The following is a description of a gene set: from publication Rhein P, Scheid S, Ratei R, Hagemeier C, Seeger K, Kirschner-Schwabe R, Moericke A, Schrappe M, Spang R, Ludwig WD, Karawajew L (PMID 17330098) species: Homo sapiens Genes down-regulated in ALL (acute lymphoblastic leukemia) blasts after 1 week of treatment with glucocorticoids. Human Gene Set: RHEIN_ALL_GLUCOCORTICOID_THERAPY_DN In childhood acute lymphoblastic leukemia (ALL), persistence of leukemic blasts during therapy is of crucial prognostic significance. In the present study, we address molecular and cell biologic features of blasts persisting after 1 week of induction glucocorticoid therapy. Genome-wide gene expression analysis of leukemic samples from precursor B-cell ALL patients (n=18) identified a set of genes differentially expressed in blasts at diagnosis day 0 (d0) and persisting on day 8 (d8). Expression changes indicate a shift towards mature B cells, inhibition of cell cycling and increased expression of adhesion (CD11b/ITGAM) and cytokine (CD119/IFNGR1) receptors. A direct comparison with normal B cells, which are largely therapy resistant, confirmed the differentiation shift at the mRNA (n=10) and protein (n=109) levels. Flow cytometric analysis in independent cohorts of patients confirmed both a decreased proliferative activity (n=13) and the upregulation of CD11b and CD119 (n=29) in d8 blasts. The differentiation shift and low proliferative activity in d8 blasts may account for the persistence of blasts during therapy and affect their sensitivity to further therapeutic treatment. CD11b and CD119 are potential specific markers for d8 blast persistence and detection of minimal residual disease, which warrant further investigation., and this is the list of marker genes: CNBP, RSL1D1, FOS, PAICS, CFAP298 (NCBI Gene Id 89757), GIMAP6, MCM5, CYB5A, CCT7, GPI, COPS6, NUP37, SET, VRK1, GINS2, CCT3, SPARC, LDHB, MIS18A, SNRPE, PAK2, PCMT1, PARK7, HMMR, RPL3, DTL, NSD2, MDH1, TCFL5, GDI2, ING2, HMGN2, FABP5, METTL5, RHOA, IGFBP7, GOT2, PDIA6, PRORP, SMC1A, SPTSSA, ADGRA3, KCTD3, CEP55, PSMA6, PRDX1, CDC25A, PRDX3, EHBP1 (NCBI Gene Id 23301), IARS2, COX11, CSNK2B, LDHA, RACGAP1, HEBP1, TMEM135, PRMT1, UBE2L6, GMPS, GBE1 (NCBI Gene Id 2632), MCM2, TTK, PRIM1, ATP5F1C, MTHFD1, MRPS35, CCDC90B (NCBI Gene Id 60492), ARMCX1, HMGA1, PRKDC (protein kinase, DNA-activated, catalytic subunit), SERPINE1, RTCA, MARCKSL1, PDLIM1, LAPTM4B, HSPB1, ATIC, NDUFA8, EGR3, CYFIP1, PGD, GGCT, CEP57, ENSG00000275616, SSBP1, SMS, NUDT1, BLNK, NME1, PIGP, SHMT2, MIF, RBM8A, MCM6, PCCB, JUN, NELFE, INTS8, GGH, DAD1 (defender against cell death 1), H3C10, ATXN10, EPRS1, HSPA8, H3C4, PRC1, NDUFA10, LSM4, PCLAF, OLA1, SMC2, KIF15, CD34, ATP5PF, RPL23, HACD1, ASAP2, ADSL, ACAA2, RPL31, CKS1B, CYTL1, TUBB, ECT2, POLE2, MYH10, CANX, CENPN, LTA4H (NCBI Gene Id 4048), PSMB2, BCCIP, ANP32A, CENPU, PKD2, DUT, RPA1, ELAVL1, CEP68, GLO1, IVNS1ABP, CDK4, FLI1, CCND3, SDHC, CSRP2, GNAI1 (NCBI Gene Id 2770), PDCD2, TYMS, PSMB9, LRPPRC, UNG, SORD, NCAPG, TALDO1, ME2, TBCA, HNRNPA3P1, CCNB2, GCSH, ZWINT, IDH2, ITGB3BP, ACADM, VDAC1, GAPDH, SCCPDH, CTBP1, PRPS2, EMP1, HPRT1, DUSP6, TPI1, CKS2, PPIA, TKT, PFKM, CACYBP, FOSB, RPLP0, IPO7, AKR1A1, CCT8, DNTT, EGR1, MEST, RSU1, MPP1, RCAN1, TUBA1A, TRMT5, CREB1, DHFR, BIRC5, WASF1, MLLT11, BHLHE40, PSMG1, ALDH6A1, LXN, UQCRC2, MAD2L1, PGK1, LAT2, SNRPD2, MELK, ATP5MG, BLMH, CALM1, HPS4, NUSAP1, JADE3, DPH5, BUB1B, KLF4, SSBP2, OXCT1, DCTD, HSP90AB1, SPCS2, HDDC2, KDELR2, METAP2, GPM6B, RBMX, CD9, PSMD10, APOBEC3G, SLC5A3, NEK4, CDK1, TUBA1B (tubulin alpha 1b), ST13, FXR1, NDUFB5, MRPS33, THOC7, LSM5, SKIC8, RPL22, DYRK2 (NCBI Gene Id 8445), HAUS4, ADA, TBC1D4, DPYSL2, SAP18, MYB, TMEM14A, NASP, FHL1, ANP32B, PRKCH, TPGS2 (NCBI Gene Id 25941), HADH, CFDP1, FBL, PPA1, FRMD4B, GPX7, CNPY2, CCT6A, DARS1, PSMD14, PTTG1, RPP40, ISOC1, SHCBP1, NREP, AHCY, STMN1, HNRNPA0, RAB13, BCL2, TCF12, MEF2C, RBBP4, SLC35E3, CITED2, BCAP31, EID1 (NCBI Gene Id 27110), C1QBP (NCBI Gene Id 708), RGCC, PHYH, AHCYL1, PSMB8, ACAT1, DYNLL1, IGLL1, ERG, TOP2A, TUFM, CPNE3, MYO5C, SSRP1, ENO1, DIMT1, MME, ATP5MC3, ATRX, BARD1, RRM1, C1orf54 (chromosome 1 open reading frame 54), IMPDH2, NHP2 (NHP2 ribonucleoprotein), HNRNPA3, PXDN, ANP32E, ARPC5L, PTGDR, ETFA (electron transfer flavoprotein subunit alpha), PRDX6, NUCB2, SEPTIN11, PCNA, MAGED1, NPM1, AKAP12, UGP2, CAT, ALDH5A1, VPREB1, SERBP1, GMNN, MYO18A, CCNG1, SSR1, RRM2, TCEAL4, HNRNPC, PIN4, ZFAND1 (NCBI Gene Id 79752), BZW2, HMGN4, ESD, APEX1, PSIP1, PRDX4, CHCHD3, RTN3, MRPL3 (NCBI Gene Id 11222), KIF11, SH3BGRL, RFC4, HMGB3, CHEK1, PRPSAP1, ATP9A, TMEM97, MRC1, RAD51AP1, SCHIP1, CD99, STOML2, LINC00342, SCP2, CLNS1A, MCM4, RAD51, PCCA, STK32B, ECI2, NAP1L1, E2F8, CETN2, AK2, SNRPD3, LRIG1, MCTS1, TUBA1C